The following is a description of a gene set: A form of amyloidosis that affects the kidney. On hematoxylin and eosin stain, amyloid is identified as extracellular amorphous material that is lightly eosinophilic. These deposits often stain weakly for periodic acid Schiff (PAS), demonstrate a blue-to-gray hue on the trichrome stain and are typically negative on the Jones methenamine silver (JMS) stain. These tinctorial properties contrast with the histologic appearance of collagen, a major component of basement membranes, mesangial matrix and areas of sclerosis, which demonstrates strong positivity for PAS and JMS (See Figure 1 of ). Renal amyloidosis studied in species Homo sapiens Human Gene Set: HP_RENAL_AMYLOIDOSIS, and this is the list of marker genes: COL7A1, B2M, SLC7A7, FGA, NLRP3, LYZ, GSN, MMP1, SAA1 (NCBI Gene Id 6288), MEFV, APOA1